Given this list of marker genes Pla2g3, Adora3, Ywhaz, Rab44, Nppa, Slc22a2 (NCBI Gene Id 20518), Snap23, Lyn, Ada, Csf2, Slc29a4, Ednra, Snx4, Vamp8, Cckbr, Btk, Slc22a3, Slc18a2, Edn1, Adcyap1, here is a description of the gene set: studied in species Mus musculus The directed movement of histamine into, out of or within a cell, or between cells, by means of some agent such as a transporter or pore. Histamine is a physiologically active amine, found in plant and animal tissue and released from mast cells as part of an allergic reaction in humans. Mouse Gene Set: GOBP_HISTAMINE_TRANSPORT